Given this list of marker genes Disp2, Snhg11, Ubb-ps, Fmo1, Syndig1l, Isl1, Rbm26, Golgb1, Papss2, Cebpb, Wfs1, Lrrc10b, Akap13, Cmip, Map2k2, A230057D06Rik, Neurod1, Cdk2ap2, Sez6l2, Ivd, Ttc3 (NCBI Gene Id 70444), Slc2a2, Gmppb, Csf2ra, Actg1, Try4, Abcc8, Efna5, Srsf2, Rbm39, Dtx3 (deltex 3, E3 ubiquitin ligase), Srrm2, Nipal3, A330076H08Rik, Gns, Psap, Ece1, Ndufb9, Shfl, Ier2, Peg13, Gad1, Echdc2, Ctrb1, Gpsm1, Nkx2-2, Tle5, Grk3, Luc7l2, Nfkbiz, Eif4g1, Ins1, Sez6l, Map1b, Pnisr, Tia1, Xist, Ddb1, Tmem59l, Ptprn2, Nav2, Nfic, Pkp4 (plakophilin 4), Ddx17, Zfp516, Mt1, Clk1, Pebp1, Rian, Meg3, Kif1a, H2ap, Nap1l5, Tssc4, Kcnh2, Bet1l, Chd7, Neat1, Napa, Carmil3, Rhobtb1, Erdr1, Ftl1, Phactr1, Mlxipl, Pcx, Ubc (ubiquitin C), Kdm6b, Ddc, Tsc22d1, Ubb, Tuba1a, Mbd6, Cfl1, Fos, Acly, Rnf182, 2900005J15Rik, Ins2, Pcsk2 (NCBI Gene Id 99080), Ank2, Guk1, Cirbp, Sf3b2, Chka, Adgrl1, Matn2, Phf1, C2cd4b, Madd, Ddx39b, Ncor1, Pycr2, Rsrp1, Ptprn, Ucn3, Socs2, Ddx5, Pkdcc, Celf3, Fbxl16, Cela1, Inpp4a (inositol polyphosphate-4-phosphatase, type I), Wnt4, Nktr, Baiap3 (BAI1-associated protein 3), Herpud1 (homocysteine-inducible, endoplasmic reticulum stress-inducible, ubiquitin-like domain member 1), Mapk15, Arglu1, Ckb, Prnp, Jund, Ncoa1, Irf2bp2, Fam151a, Syt7, Socs3, Zscan26, Selenos, Mafg, Eprs1, Gadd45g, Hspa5, Prkcb, Dusp1 (dual specificity phosphatase 1), Foxp4, Rsrc2, Cela2a (NCBI Gene Id 13706), Prss53, Tmem215, Ptpa, Ip6k1 (inositol hexaphosphate kinase 1), Rasd1, Nisch, Tshz1, C1qa, Unc80, Gm13498, Adamts2, Nkx6-1, Rab3a, Impact, Smarca4, Zfhx2, Pcsk1n, Actb, Srsf5, Emilin1, Prss2, Srsf7, Junb, Hadh, Atp2a2, Aldoa, Tmed9, Fosb, Prkca, Siah2, Kif12, Peg3 (paternally expressed 3), Btg2 (BTG anti-proliferation factor 2), Mt2, Ctdspl (CTD small phosphatase like), Ddit3, Preb, Samd4b, Zc3h3 (zinc finger CCCH type containing 3), Ttc28, Chga, H3f3b, Malat1, Insm1, H1f2, Serpina3i, Clps, Atf5, Insrr, Tcf25, Mycbp2, Igfals, Ldlr, Nupr1, Gmppa, Son, Egr1, Srm, Jun, Gnb2 (guanine nucleotide binding protein (G protein), beta 2), Sertm1, here is a description of the gene set: species: Mus musculus Mouse Gene Set: TABULA_MURIS_SENIS_PANCREAS_PANCREATIC_BETA_CELL_AGEING from publication Tabula Muris Consortium (PMID 32669714)